The following is a description of a gene set: Any process that modulates the frequency, rate or extent of glial cell proliferation. Human Gene Set: GOBP_REGULATION_OF_GLIAL_CELL_PROLIFERATION studied in species Homo sapiens, and this is the list of marker genes: NF2, ASCL2, SOX11, UFL1, ETV5, SHH, RNF10, DICER1, KRAS, NOTCH1, LTA, ABCC8, TSPO, E2F1, PRKCH, PRKCI, MIR222, HES1, SOX10, CERS2, RB1 (RB transcriptional corepressor 1), GFAP, MECP2, PPP1CC, MIR146A, MIR221, CREB1, MIR125B1, TNF, ATXN1, TP53, MYB, IL1B, PLAG1, CHRM1, SLC7A5, LYN, VEGFC (NCBI Gene Id 7424), IDH2, SKI, IL6, NF1, NTN1